Given this list of marker genes Slc17a8, Arhgef11, Psen1 (presenilin 1, NCBI Gene Id 19164), Arl6ip1, Itgb1, here is a description of the gene set: Mouse Gene Set: GOBP_POSITIVE_REGULATION_OF_L_GLUTAMATE_IMPORT_ACROSS_PLASMA_MEMBRANE studied in species Mus musculus Any process that activates or increases the frequency, rate or extent of L-glutamate import into a cell.